The following is a description of a gene set: Repulsive Sema4D-Plexin-B1 signaling involves four GTPases, Rnd1, R-Ras, Rho and Rac1. Sema4D-Plexin-B1 binding promotes Rnd1-dependent activation of the plexin-B1 GAP domain and transient suppression of R-Ras activity. R-Ras inactivation promotes PI3K and Akt inactivation followed by GSK-3beta activation and CRMP2 inactivation. Plexin-B1 also transiently associates with and activates p190Rho-GAP, triggering a transient decrease in activated Rho. part of: Sema4D in semaphorin signaling Reactome Pathway: Sema4D mediated inhibition of cell attachment and migration studied in species Homo sapiens, and this is the list of marker genes: SEMA4D, RAC1, PLXNB1, RRAS, ARHGAP35, MET, RHOA, RND1